The following is a description of a gene set: A protein complex which is capable of protein kinase activity. Human Gene Set: GOCC_PROTEIN_KINASE_COMPLEX species: Homo sapiens, and this is the list of marker genes: CNPPD1, CSNK2A2, ZBTB7A, CDK8, CDK10, GTF2H1, CSNK2A1, CSNK2A3 (casein kinase 2 alpha 3), IKBKE, CCNI2, CDK12, PRKX, CDK19, CCNJ, TRAF3, STING1, STK11, PRKACB, PRKAR2B, ERC1 (ELKS/RAB6-interacting/CAST family member 1), PRKACG, PRKAR1B, MMS19, SMCR8, ERN1, ULK1, CDK2, PARD6B, RB1, CCNI, CDK3, MAPKAP1, CCNB1, PRKAB2, PRKAG3, DAPK1, CCNY, CDK7, RB1CC1, ACVR2B, UVRAG, AKAP14, CCNE2, ERCC2, STRADB, PHKB, MED12 (mediator complex subunit 12), CCNL2, IKBKB, GTF2H5, TGFBR2, ATG13 (autophagy related 13), MTOR, CCNT1, ACVR1C, CCNJL, CDK5R1, TBC1D5, CCNF, RPTOR, GTF2H2C_2, XRCC6, ACVR2A, PCNA, AKAP4, ACVR1B, TGFBR1, CDK13, PRKCI (protein kinase C iota), CDK14, CSNK2B, PHKA2, XRCC5, CCNB3, PHKG1, IRS1, DBF4, CCNT2, CCND3, C9orf72 (NCBI Gene Id 73205), BCCIP, CDK11A, GTF2H3, CCND1, NEK10, ACVR1, PRKAA2, CCNH, IGF1R, CDK6, MED13, MNAT1, PRKAR1A, SESN2, INSRR, CAB39, CCNO, PRKAG2, CCNA2, CCNC, CCNA1 (cyclin A1), PRKAR2A, PRKAA1, CDK16, ERCC3, CDK4, CHUK, TBK1, CAB39L, CCNQ, CDK1, CDK9, PARD6G, PRKY, CCNG2, TBKBP1, PARD6A, PYDC1, CCNP, ATG101, CCNL1, CDKN2D, STRADA, PSG9, PHKG2, CCNG1, MLST8, PRKAG1, CDK5R2, CDK11B, PHKA1, CKS2, CKS1B, PRKCZ, MAP3K5, IKBKG, CCNE1, RICTOR, LAS1L, SNW1, CDK5, GTF2H2, AZI2, CCNK, CCNB2, TANK (TRAF family member associated NFKB activator), INSR, PRKAB1, CCND2, PRKACA, CDKN1A, IFIT5, DBF4B, TRIM40, GTF2H4, PYCARD, PARD3, PRKDC, GTF2H2C